Given this list of marker genes PSMD14, PSMC5, PSMC6, IDE, UBQLN4, here is a description of the gene set: Human Gene Set: GOCC_CYTOSOLIC_PROTEASOME_COMPLEX studied in species Homo sapiens A proteasome complex found in the cytosol of a cell.